The following is a description of a gene set: Genes predicted to be targets of miRBase v22 microRNA hsa-miR-18b-3p in miRDB v6.0 with MirTarget v4 prediction scores > 80 (high confidence targets). species: Homo sapiens from publication Chen Y, Wang X (PMID 31504780) Human Gene Set: MIR18B_3P, and this is the list of marker genes: PANK2, TMEM150A, INPPL1, ZC3H8, ZNF644, FAM110B, SHMT2, NEK2, RALGPS2, SHC1, VAMP7, PLCXD3, RGS7BP, ANKRD12, PLCE1, SLC12A2, IP6K2, RAB30, RAD21 (RAD21 cohesin complex component), ZNF143, NOVA1, NOC3L, RHOXF2, ARK2N, MINDY2, STOX2, RHOXF2B, CDKL1, LRRC17, LVRN, GUCY1A2, VPS13B, PLPPR2, OR11A1, BRD8, RAB10, PPARGC1B, CTDSPL2, PM20D1, KCNRG, GPR137B, SERINC5 (NCBI Gene Id 256987), NFE2L1, FLT3 (fms related receptor tyrosine kinase 3), PAFAH1B1, LRP3, ITGB1, NQO1, RTN4RL2, USP48, BCO2, ZNF483 (zinc finger protein 483)